Given this list of marker genes RAMP2, RAMP1, RAMP3, CRCP, CALCRL, CALCR, here is a description of the gene set: studied in species Homo sapiens Human Gene Set: GOMF_CALCITONIN_FAMILY_RECEPTOR_ACTIVITY Combining with any member of the calcitonin family (e.g. adrenomedullin, adrenomedullin 2 (intermedin), amylin, calcitonin and calcitonin gene-related peptides (CGRPs)) to initiate a change in cell activity.